The following is a description of a gene set: A reduction in the activity of the mitochondrial respiratory chain complex I, which is part of the electron transport chain in mitochondria. studied in species Homo sapiens Human Gene Set: HP_DECREASED_ACTIVITY_OF_MITOCHONDRIAL_COMPLEX_I Decreased activity of mitochondrial complex I, and this is the list of marker genes: ISCU, MT-TE (NCBI Gene Id 4556), NARS2, NDUFA12, DGUOK, OPA1, FBXL4, MRPL12, SLC25A26, NDUFAF8, MTFMT, NDUFAF4, NDUFA8, MECR, NDUFS8, MT-TL1, TEFM, TIMM22, NDUFS4, SLC25A4, TAMM41, FLAD1, CRLS1, SUCLG1, SCN4A, AARS2, NDUFS1, VARS2, MRPS22, NDUFA10 (NADH:ubiquinone oxidoreductase subunit A10), NDUFB8, NUBPL, NDUFV2, NDUFB9, NDUFS2, GATC, TXN2, TRMU, TSFM, NDUFS7, MTRFR, NDUFV1, CARS2, NDUFS3, TRMT10C, NDUFAF2, FOXRED1, TIMMDC1, MRM2, BOLA3, MRPL39, NDUFAF6, NDUFB10, MRPS23, AGK, ATP5F1A, NDUFAF5, IBA57, NDUFS6, MRPS16, NDUFA13, TRMT5, PTCD3, NDUFA1 (NADH:ubiquinone oxidoreductase subunit A1), MT-ND1, YARS2, NDUFA9, EARS2, NDUFB3, UQCC2, SLC25A10, MT-ND3, NDUFB7, MT-ND2, GTPBP3, POLG, PUS1, NDUFB11, ISCA2, NDUFC2, NDUFA6, MIEF2, NDUFA11, RARS2, MGME1, TMEM126B, NDUFAF1, ELAC2, TK2, SFXN4, TRIT1, MRPS14, GFM1, MPV17, QRSL1, NDUFA2, ACAD9, NSUN3, C1QBP, NDUFAF3